Given this list of marker genes Ppp2r1a, Dynll1, Kif2a, Nup107, Dync1i1, Cenps, Cenpn, Rps27rt, Cenpq, Ppp1cc, Kntc1, Kif2c, Cenpk, Cenpu, Cenpf, Ska1, Mad2l1, Nup37, Ndel1, Cenpi, Rangap1, Ppp2r5e, Ppp2r5a, Ppp2r5d, Clasp2, Sec13, Ckap5, Cdca8, Cenpo, Cenpt, Ppp2ca, Nup133, Taok1, Clasp1, Ranbp2, Nsl1, Ska2, Itgb3bp, Kif18a, Cenpp, Xpo1, Bub1b, Dync1li1, Cenpe, Mad1l1, Ahctf1, Incenp, Zw10, Rps27, Sgo1, Spdl1, Mapre1, Dync1i2, Cenph, Nuf2, Nup160, Nup43, Rcc2, Ppp2cb, Cenpm, Ndc80, Ppp2r5c, Bub3, Ercc6l, Dynll2, Nde1, Spc24, Nudc, Pmf1, Aurkb, Dsn1, Pafah1b1, Cenpa, Dync1h1, Mis12, Cenpc1, Cenpl, Plk1, Dync1li2, Zwint, Nup85, Kif2b, Ppp2r5b, Ppp2r1b, Nup98, Zwilch (NCBI Gene Id 68014), Clip1, Spc25, Cdc20, B9d2, Bub1 (NCBI Gene Id 99145), Seh1l, Sgo2a, here is a description of the gene set: Amplification of signal from the kinetochores species: Mus musculus Mouse Gene Set: REACTOME_AMPLIFICATION_OF_SIGNAL_FROM_THE_KINETOCHORES